Given this list of marker genes Wnt7b, Fgf8, Mapk8ip3, Tgfbr2 (NCBI Gene Id 76304), Pitx2, Foxp2, Celsr1, Tnc, Bmp4 (NCBI Gene Id 12159), Plod3, Pdgfra, Ctsh, Kras, Wnt2, Srsf6, Spry2, Tcf21, Shh, Dag1, Esrp2, Hoxa5, Ext1, Sec24b, Nog, Gata4, Lif, Ctsz, Ctnnb1, Tmem67, Foxf1, Tnf, Hmga1, Tmtc3, Esrp1, Map2k1, Sox11, Dlg5, Hps1, Wnt2b, Fgf7, Nodal, Mapk3, Sox9, Spry1, Ap3b1 (adaptor-related protein complex 3, beta 1 subunit), Nkx2-1, Col6a1, Lama1, Sox2, Yap1, Rdh10, Srf, Rpl13a (NCBI Gene Id 80550), Mapk1, Fgfr2, Ctsl, Ctsd, Fgf10, Hhip, Foxa2, Map2k2, Dspp, Hhex, Cdc42, Hipk2, Id1, Foxa1, Igf1, Rspo2 (R-spondin 2), Hmga2, Nfib, Tbx2, Cfc1, Grhl2, Vangl2, Stk40, here is a description of the gene set: studied in species Mus musculus The process in which the anatomical structures of the lung are generated and organized. Mouse Gene Set: GOBP_LUNG_MORPHOGENESIS